Given this list of marker genes UVSSA, INO80E, TNKS, ATAD2, ECT2, VPS52, DNAJB2, RPS6KA5, PDE4A, RNF187, ITGA4, TADA3, TNRC6B, LBR, CAP1, UQCR10, PASK, SWI5, HNRNPUL1, MCUB, IFT74, CBR4, DYNC1LI2, MED25, THEMIS2, NCKAP1L, NUDT16L1, TRIM38, ZFAND2B, CCPG1 (NCBI Gene Id 9236), SLC25A25-AS1, ABR, RCOR3, NF1, ZSCAN16, EPB41, DECR1, PPP1R21, BTN3A3, SYTL1, ARL2 (NCBI Gene Id 402), NDC80, RABGAP1L, TMEM134, ABCC5, ZFP62 (ZFP62 zinc finger protein), ATMIN, PINK1, CBX5, TSNAX, TBC1D22A, RNASEL, HNRNPU, IFFO1, HEATR5B, BCAS3, OSTF1, AP1G2, CHMP3, SLC30A6, TMEM179B, ASAH1, ALKBH7, ASXL2, SIDT2, FAM8A1, GTF2A1, MDM1, AIDA, B3GNT2, BTN3A2 (butyrophilin subfamily 3 member A2), ZFYVE28 (zinc finger FYVE-type containing 28), CISD2, TACC3, PGPEP1, PDCD4-AS1, PDE3B, CHST12, TET1, BTN3A1, MON1B, RBL1, DNASE1L1, CEP192, ELMOD2 (NCBI Gene Id 255520), TMEM218, ABTB1, LAIR1, DUT, TRAPPC12, SPG11, KRBOX4, GMPR2, LRIG2, SFR1, SAC3D1, LYPLAL1, RETREG3 (reticulophagy regulator family member 3), TAOK1, LETMD1, ZNF33A, FANCM, CNPPD1, PAN3 (poly(A) specific ribonuclease subunit PAN3), SLF1, CABIN1, UBA7, MFSD1, LRP10, YIPF1, MOB3A, METTL15, XRN1, VPS11, ABHD14A, IRAK4, CCSER2 (NCBI Gene Id 54462), FAM111A, PRIM1, MGAT4A, IDNK, TMEM154, CEP19, SNX18, TGOLN2, TMEM9B, DENND10, RGS14, DENND1C, PPOX, SSH2, GATD3, TMEM59, ZZEF1, PAQR8, CSK, HEBP2 (NCBI Gene Id 23593), FBXL17, RPS27L, SP4, SLC38A6, RPRD1A, GSDMB, HEATR5A, STUB1, ANGEL2, MARCHF8, TMEM219, ATG2A, CFAP70, OAS1, TPK1, B3GALT4, DGLUCY, PRORSD1P, HSPA1L, HELQ, WAS, GALNT3, OARD1, IRF3, CCDC77 (coiled-coil domain containing 77), RALBP1, MAN1A2, SNRPN, EEIG1, KIF11, RNF214, PDE6D, MOAP1, PCNT, ERMP1, JADE2, TAS2R14, LINC00324, CD99L2, RAC2, MAN1B1, ALKBH6, GNB5, UBAC1, EDEM2, PRMT2, PHKB, DYRK1A, KIAA2013, ZNF217, CDS2, FCSK, NMT2, ZFYVE26, HMGB2, CGGBP1, IFIH1, MAX, MAP4K2, here is a description of the gene set: species: Homo sapiens from publication Gattinoni L, Lugli E, Ji Y, Pos Z, Paulos CM, Quigley MF, Almeida JR, Gostick E, Yu Z, Carpenito C, Wang E, Douek DC, Price DA, June CH, Marincola FM, Roederer M, Restifo NP (PMID 21926977) An early-differentiated CD8+ memory T cell subset with stem cell-like properties (TSCM) can be identified within the naïve-like T cell population by the expression of CD95/Fas. Based on experiments including exon- and gene-level expression analysis, we provide evidence that this subset of antigen-specific cells represents an early precursor of conventional central (TCM) and effector (TEM) memory CD8+ T cells with enhanced self-renewal capacity and proliferative potential. We identified genes differentially expressed between major T cell subsets defined along with memory T cell commitment. Based on the analysis of these genes, CD95+ naïve T cells (TSCM) cluster closer to the CD8+ T memory compartment than to classical (CD95-) naïve T (TN) cells, and display an intermittent phenotype between classical TN and TCM cells in terms of all major T cell differentiation markers analyzed. Human Gene Set: GSE23321_CD8_STEM_CELL_MEMORY_VS_NAIVE_CD8_TCELL_DN Genes down-regulated in CD8 T cells: stem cell memory versus naïve.